Given this list of marker genes TUBGCP4, HAUS7, TUBGCP3, CEP290, MACF1, HAUS4, TUBGCP6, CAMSAP2, CAMSAP3, NUMA1, NIN, TUBGCP2, TUBGCP5, CAMSAP1, here is a description of the gene set: species: Homo sapiens Binding to the minus end of a microtubule. Human Gene Set: GOMF_MICROTUBULE_MINUS_END_BINDING